The following is a description of a gene set: studied in species Mus musculus Mouse Gene Set: GOMF_OXIDOREDUCTASE_ACTIVITY_ACTING_ON_SINGLE_DONORS_WITH_INCORPORATION_OF_MOLECULAR_OXYGEN Catalysis of an oxidation-reduction (redox) reaction in which hydrogen or electrons are transferred from one donor, and molecular oxygen is incorporated into a donor., and this is the list of marker genes: Pir, Adi1, Ido2, Ado, Hpdl, Ptgs1, Bco2, Hgd, Alox5, Alox5ap, Bco1, Alox12, Haao, Cdo1, Aloxe3, Alox12b, Ptgs2 (NCBI Gene Id 19225), Hpd, Ethe1, Rpe65, Alox12e, Alox15, Alox8, Miox, Tdo2, Ido1